The following is a description of a gene set: species: Homo sapiens Human Gene Set: GOBP_NEUROTRANSMITTER_UPTAKE The directed movement of neurotransmitters into neurons or glial cells. This process leads to inactivation and recycling of neurotransmitters., and this is the list of marker genes: SLC29A2, SLC18A1, GFAP, SLC6A1, SLC29A4, TOR1A, APP, RAB3B, SLC6A13, ATP1A2, DRD4, DRD2, NOS1, SLC6A11 (NCBI Gene Id 6538), DRD1, ITGB1, SLC1A6, SLC29A1, SLC6A2, SLC17A8, SLC6A9, DRD3, SLC18A3, SLC22A3, SLC22A2, PRKN, SLC6A12, SLC1A3, SLC18A2, PARK7, SLC22A1, SLC6A4, CLN8, ITGB3, SLC18B1, SLC38A1, SLC6A3, SNCA, SLC1A7, SNAP25, KCNJ10, SLC1A2, GDNF, GPM6B, SYNGR3, FLOT1, PER2